The following is a description of a gene set: Human Gene Set: GOBP_MEIOTIC_SISTER_CHROMATID_COHESION_CENTROMERIC species: Homo sapiens The cell cycle process in which centromeres of sister chromatids are joined during meiosis., and this is the list of marker genes: BUB1 (BUB1 mitotic checkpoint serine/threonine kinase), PPP2R1A (NCBI Gene Id 5518), MEIKIN, BUB1B, PPP2R1B